Given this list of marker genes Gas2, Brwd3, Ppp3r1, Gabra2, Tet1, Sema6d, Scai, Cldnd1, Agtr1a, Phactr4, Btg2 (BTG anti-proliferation factor 2), Bend4, Dmrt3, Hapstr1, Rbm11, Vmac, Fermt2, Kif16b, Mia3, Etv3, Or7d10, Gabra1, Nfyb, Foxn2, Adar, Eif3j2, Fry, Galnt18, Gab1, Hmbox1, Cbfb, Vash1, Adipor1, Tmem236, Kit, Ddit4, Sbk1, Exo1, Sybu, Fat2, Rnps1, St6galnac3, Trp53bp2, Megf9, Eif3j1, Creg2, Tnrc6c, Fos, Chsy1, Clvs2, Ptprz1, Arhgef7, Irx5, Bbc3, Shprh, Mark1, Rfx7, Gpr155, Sparcl1, Cdkn1b, Vapb, Plekha2, Rcbtb2, Clec1a, Mier3, Casz1, Cdk19, Plekhb2, Prrg3, Gucy1a2, Rab1a, Mapk6, Plcl2, Far1, Atp1b1, Tle3, Slfn8, Ap3b2, Dcun1d1, Zbtb4, Sun2, Fgf14, Arf4, Trim36, Upf3b, 2510009E07Rik, Gnb3, Pik3r1, Fndc3a, Tcf12, Dpp8, Hectd2, Ptbp3, Dcaf12, Pi15, Rgs6, Rfx6, Ilf2, Esr1, Mllt6, Trabd2b, Slc15a5, Hipk1, Dhx36, Syn3, Cnr1, Fmr1, Tmem165, Dennd1b, Pramel22, Rev3l (NCBI Gene Id 19714), Zfp385a, Wdr47, Tshr, Cdh2, Gnai2, Erbb4, Bcl2l11, Atosa, Mylip, Paip1, Atxn1, Brwd1, Midn, Thoc1, Zfp869, Tmcc1, Smarca5, Braf, Ralgapa1, Pramel27, here is a description of the gene set: studied in species Mus musculus from publication Chen Y, Wang X (PMID 31504780) Mouse Gene Set: MIR_222_3P Genes predicted to be targets of miRBase v22 microRNA mmu_miR_222_3p in miRDB v6.0 with MirTarget v4 prediction scores > 80 (high confidence targets).